The following is a description of a gene set: species: Homo sapiens Human Gene Set: GOBP_REGULATION_OF_GROWTH_RATE Any process that modulates the rate of growth of all or part of an organism., and this is the list of marker genes: TMPRSS4, GHRL, RFTN1, WRN, BNIPL, ARMC10